The following is a description of a gene set: Mouse Gene Set: GOBP_CARDIAC_JELLY_DEVELOPMENT The process whose specific outcome is the progression of cardiac jelly over time, from its formation to the mature structure. The cardiac jelly is an acellular gelatinous matrix secreted by the myocardium and plays a central role in the septation of the heart. studied in species Mus musculus, and this is the list of marker genes: Eng, Gata5, Tbx2, Tbx3 (NCBI Gene Id 52240), Bmp2, Bmp4